The following is a description of a gene set: species: Homo sapiens Human Gene Set: SNRNP70_TARGET_GENES from publication Yevshin I, Sharipov R, Kolmykov S, Kondrakhin Y, Kolpakov F (PMID 30445619) Genes containing one or more binding sites for (SNRNP70) in their promoter regions (TSS -1000,+100 bp) as identified by GTRD version 20.06 ChIP-seq harmonization., and this is the list of marker genes: HSPA8, RNF19B, SNORD88C, RNF149, UBR3, RPL7A, FOXA1, MRPL20-DT, BZW1-AS1, RPL18, MMP24OS, ING5, SNORD37, NCKAP5L, DDAH2, DANCR, CSE1L, SELENOP, XBP1, SEPTIN7, DNAJB4, H2BC12, CDS2, DLG4, NUP85, UFD1-AS1, IDI1, IGLV1-47, MTSS2, CPNE1, HNRNPC, STK19, SNORD38A, C11orf54, AKR1C1, ATF7IP2, HAAO, ZKSCAN2, PPM1F-AS1, MCM7, DAGLA, MFSD11, MIR3187 (NCBI Gene Id 100422854), KDM4B, BCAR1, RPS16, MT-CO2, THAP9, PABPC1L, NAIF1, DM1-AS, KRT18P5, SRSF10, DPP8, PSMG1, RAB40C, ERRFI1, PPM1F, NAP1L1, FMC1-LUC7L2, NUDT3, PAQR4, MT-RNR1, PARD6B (par-6 family cell polarity regulator beta), PRR7, THAP7, RNA5SP528, RPL17-C18orf32, APTX, SNORD12, TNRC18, HECTD1 (NCBI Gene Id 25831), NF1P6, H2AC15, ENSG00000232053, GADD45A, MTCO3P12, BIRC6, NCL, NDUFAB1, GNMT, SNORD100, C9orf163, PDE7A, MALAT1, GP6, SSBP4, RBM3, GLUL, ARL6IP6, CHERP, MIR142HG, MIEN1, NDUFA7, IQCG (NCBI Gene Id 84223), MT-TS1, PMS1, ARHGDIA, RPL27, SLC2A4RG, ZNF7 (zinc finger protein 7), MIR6832, FAAP100, MEPCE, GEMIN6, PKMYT1, H2AC13, H2BC11, RPL9, IGLV6-57, CEMP1, ENO1-AS1, IGLV4-3, NUDCD1, PPP1R15A, FNDC3B, RPS3, SNORD49A, GLRX5P3, ZEB2, CLK1, SNX21, NDST2, SNORA50C, DCXR-DT, RSF1, OSER1, SLC35C2, GAS5, SOX9-AS1, SNORD25, CEP95, FTO, RPL11, PIPOX, SNORD38B, PELP1-DT (NCBI Gene Id 101559451), TUFMP1, RNA5SP34, AIF1L, SNORD36B, SLC25A6, MT-TP, EIF4G2, SPAG4, MAZ, ZC3H10, JSRP1, UTP4, IER3-AS1, LCAT, AMBRA1, SNORA73A, NEAT1, ARL15, NFE2L1, TRAV23DV6, H2AC20, STIM1, PHF19, MSMP, COCH, IL4R, RNF32, RPL34-DT, VMP1, LZTR1, H2AC9P, ZCWPW1, PRRT3-AS1 (NCBI Gene Id 100874032), FLOT2, RNU6-407P, RPL32P3, TCEA2, MPV17, SNORA77B, ORMDL1 (NCBI Gene Id 94101), EFEMP2, SPAG5-AS1, SNORD65, NOL3, SNORD30, STAT5A, USP41P, ACADVL, NUP205, SPHK2, DTL, SEPTIN2 (NCBI Gene Id 4735), PXN-AS1, SLC20A2, CHD9, SOCS2P2, MAP3K1, RPS6KB1, H4C4, WDTC1, FASN, ARPC1A (actin related protein 2/3 complex subunit 1A), CNTNAP1, IGLV3-21, NFE2L3, GABARAP, CDK10, SNORD49B, TIGD5, BAZ1A, SNORA74D, SSR4P1, DGAT1, CYB5D1, SGSM3, RPLP0, CD320, HAGHL, BZW1, ZFPM1-AS1, DNMT3A, KRCC1, HDLBP, NFE2L1-DT, FAM13B, WDTC1-DT, RPL35, ZNF680, RPLP2, SELL, PBLD, MTND6P4, ADARB1, A2M, LBX2, SLC38A2-AS1, IGLV3-32, DHFRP2, ZNF668, ST3GAL6, ZNF280B, PFN1, ZFHX3, HNRNPA2B1, ARPC1B, TTLL3, DEAF1, RNH1, SETD5, TALDO1, SNORA78, SNORD32A, NPB, POLD1, RNU1-100P, PRPF40A, BOP1, TUBB2A, EFHB, SNORD52, SNHG1, GCKR, FGL1, KAT14, RPGRIP1L, HOXA-AS2, SMPD4P1, ERCC4, MST1P2, SNORD28, CCDC163, SQSTM1, PILRA, ENSG00000246308, SEPTIN5, MAN2C1, NKIRAS1, EEF1A1, PYGL, DNAJC9-AS1, ATP5MC1, C5orf15, SLC44A4, CHMP2A, YWHAB, ARFRP1, SNORD104, HDDC3, RPS15, LINC01287, TMEM214, TYMP, H2AC7, SNORD84 (small nucleolar RNA, C/D box 84), RN7SKP117, RPF2, TSPOAP1-AS1, MT-TK, MRPL49, FNDC4 (NCBI Gene Id 64838), IMPA2, RNU4-2, SNORD22, MAGEF1, LRRC59, ARL6IP4, H2AC6, TRIR, ARPC5L, IMMT, DDX39B, MT-ATP6, RNU6-881P, ZDHHC8, USP8, TRIB3, HSF1, C22orf39, HLF, CLIC1, WDR4, GDF5, PARN, EPC2, DDX19B, STRBP, CTBS (NCBI Gene Id 7811), SNORD36C, PYGO2, SNORD55, DNTTIP2, POLDIP3, SLC7A5P2, ENSG00000273828, ANGPTL4, TSPOAP1, PRPSAP1, RPS27AP12, DDX5, SLC50A1, PDAP1, SNORA70, ZBTB37, HNRNPAB, GMEB2, NARF, SRSF5, PRRC2A, SNHG8, PRAMENP, RALY, ANXA4, HCN3, RPL27A, MIR17HG, RSPH14, BSCL2, DDX39B-AS1, NSL1, STIL, RPS14, BRICD5, P4HB (NCBI Gene Id 94756), A2M-AS1, SNORA52, SNORD12B, YDJC, HCFC1R1, TFPI (NCBI Gene Id 7035), GPS2, SLC3A2, SLC35F5, IDUA, ZNF398, RPL41, SLC25A25, SNORD15A, CPT1C, PDXDC1, ENO3, MIR645, RPL38, DSTYK, ZNFX1, SP3, MCEE, ISG20, SLC39A6, GALNS, PYGM, RPL26, RAD17, RETREG2, LINC02777, ESYT1, SRP54, MIR3190 (NCBI Gene Id 100422899), RPL35A, CBX1, MATR3, PROCR, PTOV1, ARRDC3, ARHGAP26, EIF4A1, MT-TI, GGA3, TMEM240, SNORD99, FBF1, HMGA1, DDX17, DNAJB1 (DnaJ heat shock protein family (Hsp40) member B1), MIA2, SEC13, ABCA5, PSEN2, PRKRIP1, EMC3-AS1, ZGPAT, CPSF1, RPL12, DYNC1I2, EDC4, EXOG, TSPAN31, MBD2, RPL22P1, ASH2L, TFRC, MED15, SNORD27, ZNF34, RNVU1-2A, PYCR3, PRMT1, HSP90AB1, SNORA33, VARS2, DECR2, REPS1, PABPN1, IGLVV-66, HSDL2-AS1, TOE1 (target of EGR1, exonuclease), MLLT10, AAMDC, DAP3, MIR3143, USP49, MT-TM, CCDC138, HMGN2, IFT52, MIR6728, AMZ2P1, ZFP90, NEK8, CD2BP2-DT, NUP214, SMG1P2, CDKN1A, NDUFV3, ATP5F1B, SELENOI, CISD3, SLC25A25-AS1, WDR27, NUB1, CEP43, RPL8P5, GLO1, APOE, HBP1, BAGE2, PNKP, SNORA26, AGBL5-AS1, SNHG29, MRPL20-AS1, SNORA44, SEC23A, RNU6-225P, SNORA7A, SLC16A3, MIR4471, PYGO2-AS1, ANKRD36, CAPRIN2, LINC00612, BRD7, NME2, DHRS4L2, KRTCAP3, IGLV3-9, SCARNA2, H2BC21, FKBPL, CBX4, ITCH, GFER, MRPL19, PLIN2, FAM177A1, MAPK1, SPG7, ALDH18A1, TMC6, EPC1, DDX42 (DEAD-box helicase 42), HNRNPH1, WFDC10A, ASPSCR1, BDP1, DCXR, ARFGAP2, PRR7-AS1, CHMP1A, GPC5-IT1, COX18, MIR4655, BPTF, NLRX1, CNPPD1, UBB, COL6A1, MT-TQ, KMT2E, TMPRSS9, SLC4A2, CLDND2, SERTAD2, SPRTN, WWOX, CACYBP, JMJD8 (NCBI Gene Id 64483), HNRNPL, CBX5, PRAME, LIAS, RNF19A, NOP58, RPL8, MT-TF, LL22NC03-63E9.3, RPL37, H4C9, ACOX3, CSNK1G2, HMGB2, VN1R7P, ECHDC2, POLD3, RPS6, SECISBP2, SNHG9, TEKTIP1, CBLL1-AS1, RAB36, CCR10, CCDC183, DHRS4-AS1, RPL13, PLD1, ILF2, ATG16L2, PLXNB1, SCAMP3, SIX5, IGLJ3, FERMT3, GEMIN2, TM9SF1, TMUB1, SUPT4H1, FUS, MPV17L, H2AC8, RPS3AP37, SNORA10, ELAC1, TATDN3, LINC00261, HBBP1, RO60, GOSR1, RNU6ATAC18P, SIL1, POLG, SRCAP, PLK3, DHPS, SRP72, COG8, RPS8, RAB31, TSPYL4, MPPE1P2, FASTK, EEF2, MAFF, FRYL, SRSF2, AXIN2, MXD1, PCNA, PPP6R3, EMC3, SYNRG, RNF44, PLPPR3, NRDC, H2BC15, MIR6797, EIF4A2, SNORD96A, SSBL4P, MT-ATP8, RPS23, ACKR2, B2M, MIR1226, SNORA61, SNORD58A, H1-12P, UROD, RPL15, GSK3B-DT, PCBP2, ENSG00000275635, DEF8, GPR137, LIPT2, PHF12, TAF9 (NCBI Gene Id 6880), ABL1, ZNF341, DGKQ, SNORD2, RNA5SP243 (RNA, 5S ribosomal pseudogene 243), LINC01596, FBXW9, NOS1AP, RAB26, FBXO17, SCG5, OR2B4P, TXLNA, PATL2, MMACHC, ZNF446, SAP25, FHOD1, H2BC7, H2AZ1-DT, RPS9, SNORD14B, DICER1-AS1, PHAF1, CLTCL1, PRPF8, MKLN1-AS, HM13, TNRC6C, CSNK1D, PRPS2 (phosphoribosyl pyrophosphate synthetase 2), SLMAP, ZNF76, ADRM1, MORF4L1, LINC01719, FABP1, SMG1P3, NARF-AS2, SNORA64, SNORD68, C5orf24, XPO7, SLC39A10, SERPINA1 (serpin family A member 1), FAM230J, PLCD3, PSMD3, RAB37, RNVU1-31 (NCBI Gene Id 124904619), H2BC4, MIR1302-3, SMG1P1, WDR37, SNORA17B, SNHG4, VARS1, CD63, SPTBN1-AS2, TLCD1, MDM4, MT-ND2, ATAD3B, MFSD3, KLF4, DYRK1A, IGLVIV-59, ZNF276, TACC3 (transforming acidic coiled-coil containing protein 3), SRSF7, CYC1, THAP7-AS1, ZKSCAN2-DT, CCDC78, SMARCC1, CBFB, SUCLG1, KAT8, RPL19, CCDC47, IKBKG, H2AC11, PPP1R3E, AMD1, NFKBIZ, THOC6, CUL7, KIAA1958, RPS5, RRAS, WEE1, H2BC17, ASPH, AAK1, DXO, GALK2, MBTD1, TRMT2A, TRAV39 (T cell receptor alpha variable 39), P2RX6, MAP3K4, SMIM47, OARD1, SNORD46, MAML3, LRRC41, FGFR4, STXBP5, PIDD1, TBX2, SRSF6, RRM2, RPS2, STAT5B, NFYC-AS1, OTX1, ITGAE, HNRNPA1, CROCCP2, RNA5SP242, SELENOH, RILP, MRPL18, PLA2G12A, CCDC34, CDC45, SLC38A10, BOLA1 (bolA family member 1), TM4SF1, RPL5, TASP1, FIZ1, RPS24, DHRS2, MIR5087, UBC, EIF1, CENPBD1P, MIMT1, ELP2, SNUPN, DHX35, NUDT17, YPEL1, FUT11, EEF1DP3, AFG3L1P, EHMT1, TPM1, H2BC8, KCNC3, QRFP, ZNF581, XPO6, FAM13B-AS1, UBE2C (NCBI Gene Id 11065), LINC01029, SNAP47, SNTB2, BCR (BCR activator of RhoGEF and GTPase), JPT1, COMT, GSK3B, RPL13A, CHD2, NCOA3, TRAPPC14, WASF2, H2BC26, PTPN23-DT, HAPSTR1, TRAV22, ZWILCH, ARHGAP5, MIR3178, ZNF580, CCDC106, RCC1, SEPTIN7-DT, SNORD110, AHCY, DEPP1, CDR2, HMOX2, HIRA, TCP1, EMP2P1, CYREN, SIVA1, MRPL40, MIDN, SND1, H4C10P, NOP56, SNHG3, SRCIN1, ZNF646, SNORD26, DUX4L18, CBLL1, SNORA71D, SNORD101 (small nucleolar RNA, C/D box 101), H3-3B, LINC01970, DSP-AS1, NACA, SNHG32 (NCBI Gene Id 50854), NSFL1C, LRFN2, PPP1R10, APRT, NECAB3, RSKR, ZNF280A, TEDC1, MRPS18B, CD2BP2, SNORD48, LUC7L2, HSD17B4, CUTALP, SMAD5, SPATA4, NFE2L2, MT-TD, CEP250, DBF4P2, AK6, ACTR3C, CUL9, RHBDL1, SNAPC5, UBE2L3, G6PD, MUTYH, MTND5P11, SPHK1, SCRIB, PPIL2, SNORA25, SIRT1, NFYA, RANBP1, IRF2BP2, COX7A2L, SLC25A10, KBTBD2, RPS19, EVA1A, TUT4, LINC02629, LRSAM1, NIP7, CCNL2, MSL1, EEF1D (NCBI Gene Id 87167), WDPCP, SNORA32, SREBF1, HASPIN, VPS52, SYCE2, AGBL5, ZFAS1, PUSL1, ZNF767P, SNORD58B, THAP9-AS1, MTHFS, RPL36A, MOV10, TMC4, NOXO1, MZF1-AS1 (MZF1 antisense RNA 1), AURKB, EIF2B1, NAA38, FAM76B, YWHAZ, RBM12, RPL30, TYMSOS (TYMS opposite strand RNA), TOP3B, RPL39, ANO5, SLC35B2, RACK1 (NCBI Gene Id 90938), SVIL, OAZ1, MIR126, PPIAP4, RPL17, MAT2A, TMEM223, PDE7A-DT, MTHFR, IGLVVI-22-1, TRNT1, RNU6-512P, RPL6P22, C6orf47, TMED1, RPL10, THUMPD3-AS1, RPL23A, SNORA24, MIR6816, ACSM3, INPP5A, GCAT, API5 (NCBI Gene Id 95494), YJU2B, ENSG00000240687, EPS8L2, CD68, FLOT1, GOT2, UCKL1, SNORD59A, QKI, SEMA7A, NOP14, RING1, YIF1B, CEP68, SLC38A2, RPL32, MLXIPL, SNORA72, GGA2, SUMF2, GYS1, RPS10, NBPF1, CBX3 (NCBI Gene Id 82756), SET, TUBB, H2AC12, WDR24, DYNLRB1, BCRP2, SSC4D, MUC20-OT1, ITGB1BP1, SNORD35B, ROCK2, RNU6-541P, C19orf48P, RNA5S12, SMARCE1, SNORD36A, FAM83E, MSMO1, MIR7111, RPS13, MPHOSPH10, PPP1R35-AS1, BTK, KANSL1L, ACAP3, DICER1, RPS15A, RBM39, B3GALT4, PILRB, MIR4512, RPL6, TARDBP, TNFSF10, SNORD70B (NCBI Gene Id 109616995), RPL3, OSER1-DT, LIMS2, ZNF524, DNASE1L2, SNORD12C, RABGGTA, NXF1, GP1BB, FMC1, ETF1P1, RPL38P2, SNORD42B, C16orf87, ACTB, NUDCD2, QRICH2